The following is a description of a gene set: species: Homo sapiens from publication Chen Y, Wang X (PMID 31504780) Human Gene Set: MIR103B Genes predicted to be targets of miRBase v22 microRNA hsa-miR-103b in miRDB v6.0 with MirTarget v4 prediction scores > 80 (high confidence targets)., and this is the list of marker genes: TGFBI, UBE2J1, HIKESHI, PPARD, CADM2, ZCWPW1, SRD5A1, ZDHHC9, HILPDA, SGTB, SNX27, SATB1, CXCL9, RNF112, EIF2B2, NAP1L2, LRRC59, FBXO34, CLCA2, GLDN, KCND2 (potassium voltage-gated channel subfamily D member 2), FAM171B, RDX, SLCO3A1, MSANTD2, DSC3, SHOC2, ZNF805, AMMECR1L, CCNI2, ESS2, RIPK4, C1orf87, SMIM43, ARFIP2, RTCA, CFC1, SMG1, DENND5A, GHR, VAMP3, CDCA2